Given this list of marker genes Gas6, Rac2 (Rac family small GTPase 2), Qsox1, Vegfb, Gna14, Fam3c, Mpig6b, Serpina3f, Gna11, Itga2b, Cyb5r1, Igf1, Dagla, Rhoa, Wdr1, Lefty2, Gng8, Gng10, Dgki, Pecam1, Fyn, Shc1, Mmrn1, Prkch, Ptpn11, Rarres2, Nhlrc2, Syk, Rasgrp2, Gp6, Serpine1, Stxbp2, Adra2c, Pik3r6, Rapgef3, Itpr3, Itih3, Gp5, Clec3b, Ptk2, Dgkq, Timp1, Vcl, Rap1b, Tagln2, Gng12, Aldoa, Tgfb1, Gnb4, Lyn, Serpina1b, Cdc42, Orm2, Lat, Selenop, Fcer1g, F8, Cdc37l1, Apoh (NCBI Gene Id 11818), Dgke, Gnb1, Itgb3, Lamp2, Gna13, Rab27b, Thbs1, Pros1, Dgka, Ahsg (alpha-2-HS-glycoprotein), Src, Apoa1, Aamp, Pik3ca, Hgf, Maged2, F2r, Vegfd, Mapk14, A1bg, Vav3, Tmsb4x, Gp1ba, Pik3r5, Stxbp3, Cd36, Timp3, Gnb5, Itpr2, Pdgfa, Manf, Ctsw, Hrg, Gng5, Ywhaz, Dgkg, Calm2, Clu, Lcp2, Lck, Pf4, Vwf, Gng4, Fn1, Endod1, Rap1a, Gng3, Ptpn1, Raf1, Cd109, Actn1, Tgfb2 (transforming growth factor, beta 2), Serpinf2, Ly6g6f, Plcg2, Dgkk, Actg1, Pcyox1l, Serpina1c, Egf, Orm3, Vegfa, Csk, Bcar1, Adra2a, Prkce, Apbb1ip, Sos1, Flna, Fga, Tex264, P2ry1, Selp, Lhfpl2, Habp4, A2m, Fgb, Rasgrp1, Pla2g4a (phospholipase A2, group IVA (cytosolic, calcium-dependent)), Abhd6, F13a1, Igf2, Serping1, Rhob, Adra2b (adrenergic receptor, alpha 2b), Alb, Pik3r2, Pik3r3, Cfd, F2rl2, Gng7, Pik3cb, Gnat3, Srgn, Kng2, Cd9, Pik3cg, Actn4, Crk, Vav1, Akt1, Calm3, Gng13, Sccpdh, Gnaq (guanine nucleotide binding protein, alpha q polypeptide), Itih4, Gp1bb, Sod1, Chid1, Vti1b, F2rl3, Mapk3, Abhd12, Prkcb, App (amyloid beta precursor protein), Brpf3, Trpc7, Lgals3bp, Islr, Tuba4a, Mapk1, Daglb, Arrb2, Ecm1, Psap, Gngt2, Dgkb, Pcdh7, Orm1, Arrb1, Abcc4, Plek, Gng2, Aplp2, Gnb2, Fgg, Calm1, Gtpbp2, Ppbp, Mgll, Dgkd, Gnb3, Phactr2, Actn2, Sparc, F2, Tor4a, Tln1, Pdgfb, Sytl4 (NCBI Gene Id 27359), Grb2, Ola1, Trpc3, Gna12, Col1a2, P2ry12, Pdpk1, Plg, Rhog, Apool, Tgfb3, Prkcq, Pik3r1, Lefty1, Dgkz (NCBI Gene Id 352984), Vegfc, Trpc6, Gna15, Dgkh, Prkcd, Vav2, Tmx3, Itpr1, Pdpn, Prkcg, Cd63, Anxa5, Ptpn6, Tbxa2r, Scg3, Spp2, Gngt1, Gnai2, Gp9, F5, Clec1b, Stx4a, Trf, Gnai1, Gnai3, Rac1, Col1a1, Gng11 (guanine nucleotide binding protein (G protein), gamma 11), Fermt3, Cyrib, Rapgef4, here is a description of the gene set: Mouse Gene Set: REACTOME_PLATELET_ACTIVATION_SIGNALING_AND_AGGREGATION Platelet activation, signaling and aggregation species: Mus musculus